Given this list of marker genes ACOT1, PPIAL4A, DPPA3, CFHR4, OR4S2, OR4M2, APOBEC3B, GDF3, MACROD2, GPSM2, H3-7, H2AC18, APOBEC3A, CES1, ZNF630, LPA, NME7, HERC2P3, LCE3E, AHNAK, OR2T11, ZDHHC11, OR2T34 (NCBI Gene Id 403243), OR51A2, TMEM167B, OR4P4, HEATR4, TUT1, MTA2, HLA-B, OR2T10, CLEC4C, MTMR8, ELAPOR1, RBFOX1, OR2A1, POTEB, AMER1, H4C14, OR4C11, CLCC1, ZDHHC14, ASB12, H2BC21, APP, HLA-C, CFHR1, TEX28, HLA-DRB5, LINC02591, GSTT1, CFHR2, PTPN20, PDXDC1, H2AC21, OR4C6, CES1P1, H2AC20, OR4N4, RHD, TAF13, FCGR1A, AMY2A, SLC2A14, OR2A42, EEF1G, BCAR3, NEGR1, NANOG, FRMPD2, OR51A4, WDR47, NRXN3, BTNL8, here is a description of the gene set: from publication Camps J, Grade M, Nguyen QT, Hörmann P, Becker S, Hummon AB, Rodriguez V, Chandrasekharappa S, Chen Y, Difilippantonio MJ, Becker H, Ghadimi BM, Ried T (PMID 18316590) Genomic aberrations on chromosome 8 are common in colon cancer, and are associated with lymph node and distant metastases as well as with disease susceptibility. This prompted us to generate a high-resolution map of genomic imbalances of chromosome 8 in 51 primary colon carcinomas using a custom-designed genomic array consisting of a tiling path of BAC clones. This analysis confirmed the dominant role of this chromosome. Unexpectedly, the position of the breakpoints suggested colocalization with structural variants in the human genome. In order to map these sites with increased resolution and to extend the analysis to the entire genome, we analyzed a subset of these tumors (n = 32) by comparative genomic hybridization on a 185K oligonucleotide array platform. Our comprehensive map of the colon cancer genome confirmed recurrent and specific low-level copy number changes of chromosomes 7, 8, 13, 18, and 20, and unveiled additional, novel sites of genomic imbalances including amplification of a histone gene cluster on chromosome 6p21.1-21.33 and deletions on chromosome 4q34-35. The systematic comparison of segments of copy number change with gene expression profiles showed that genomic imbalances directly affect average expression levels. Strikingly, we observed a significant association of chromosomal breakpoints with structural variants in the human genome: 41% of all copy number changes occurred at sites of such copy number variants (P < 2.2e(-16)). Such an association has not been previously described and reveals a yet underappreciated plasticity of the colon cancer genome; it also points to potential mechanisms for the induction of chromosomal breakage in cancer cells. Genes from chromosomal copy number losses in a panel of 51 primary colon carcinoma samples. Human Gene Set: CAMPS_COLON_CANCER_COPY_NUMBER_DN species: Homo sapiens